Given this list of marker genes SCN5A, NPPA, TRDN, CASQ2, GJA5, RYR2, here is a description of the gene set: Human Gene Set: HP_ATRIAL_STANDSTILL Atrial standstill studied in species Homo sapiens Atrial standstill or silent atrium is a rare condition presenting with the absence of electrical and mechanical activity in the atria. It presents with the absence of P waves, bradycardia, and wide QRS complex in the electrocardiogram.